The following is a description of a gene set: Genes containing one or more binding sites for (Hnrnpk) in their promoter regions (TSS -1000,+100 bp) as identified by GTRD version 20.06 ChIP-seq harmonization. Mouse Gene Set: HNRNPK_TARGET_GENES from publication Yevshin I, Sharipov R, Kolmykov S, Kondrakhin Y, Kolpakov F (PMID 30445619) studied in species Mus musculus, and this is the list of marker genes: Hspb9, Gtf3c6, Odc1, Polg, Dapk3, Atxn2l, Chrac1, Mettl23, Abcg2, Baz1b, Enc1, Atn1, Tmem131, B3gnt7, Chmp2a, Trip12 (thyroid hormone receptor interactor 12), Gtf2a1, Mblac1, 4930589L23Rik, Ube2j2, Arrdc3, Ftl1, Spata24, Zfp64, Acp6, Epo, Gramd2a, Ywhag, Zfp706, Snord3a, 2410006H16Rik, Mir7091, Grcc10, Zfp335, Wnt8a, Snord49b, Suz12, C920006O11Rik, Fignl1, Sf3a1, Thap1, 4930477E14Rik, Cln6, Zfp609, Ociad1, H2bc6, Ap1g1, Gm12279, Otub1, Cpsf1, Brd2, Rpl41, Fbxl16, Oxa1l, Fbxo36, Pole4, Arid1b, H3c7 (NCBI Gene Id 260423), Zfp513, Cchcr1, Midn, Arpc1b, H2ac8, Cux2, Ccdc157, Pxk, Gm20609, Cpt1c, Brwd1 (NCBI Gene Id 93871), Shfl, Ubb, Trmt13, Dag1, Cltc, Kat6a, H2bc13, Btbd1, Rnu7, Snord49a, Sass6 (NCBI Gene Id 72776), Gm11962, Ccnb1, Ywhae (tyrosine 3-monooxygenase/tryptophan 5-monooxygenase activation protein, epsilon polypeptide), Esrra, Aurkaip1, Ddb2, Ccnb1ip1, Fam89b, Eapp, Edc4, Nup85, Pkm, Matr3, Dynll1, H2az1, Mir290a, Lrrc3, 9030622O22Rik, A330074K22Rik, H3c6, Fdx2, H2ac13, Zfp62, Qrich1, Mir1894, Phospho1, Mir124a-1, Gm13830, Gm43403, Gnb2, Pou5f1, Atf7ip, H2bc8, 1700025G04Rik, Hsp90aa1, 4930527J03Rik, Gm26654, Smc3, Cdk8, Eif4a2, Klhdc2, Lamp1, Kctd5, Nus1, Cisd3, Gm11398, Kmt2a, Vangl2, Znrf1, H3c15, Tcf19, Fnip2